Given this list of marker genes WIZ, ZNF354C, SNAI1, ZFAT, NEUROD1, MITF, ALX3, ZBTB38, ZNF181, ZNF134, PATZ1, STK16, NR1I3, ZNF260, RBMX, ZNF784, ZNF280C, ZNF468, FOXO3, KLF13, STAT5A, ZNF14, ZNF347, ZNF354B, ZKSCAN8, GCM1, GLIS1, TCF23, TEAD4, ZIM3, ZNF66, ZFP28, ZNF304, ONECUT1, HOXD8, HOXC9, RUNX1, NKX2-4, NFE2L2, ZNF8, NEUROG1, ZNF852, ZBTB10, LHX3, ZNF140, SOX18, RFX6, TBX10, ZNF18, PGR, ZNF555, SOX3, ZNF146, SATB1, RHOXF2B, ZNF671, ZNF577, ZBTB43, ZNF668, ZNF875, NRL, ZNF789, RAX, POU4F2, TEAD3, ZBTB25, HMGA1, ZNF236, TBX3, ZNF221, ATOH1, TWIST1, ZNF723, PROP1, FOXO6, EBF1, IKZF2, MEF2D, NR2E1, HOXD3, AIRE (autoimmune regulator), HDGF, CDK9, HSF2, MLXIPL, USF1, E2F5, ELF3, ZNF714, ZNF382, ZNF572, ZSCAN5DP, KLF1, E2F8, KLF14, BARX1 (NCBI Gene Id 56033), ESX1, PAX6, ZNF774, ESRRA, TBXT, HOXA10, TBX6, RAX2, ZNF735, FOXO3B, PHOX2B, ZNF614, KLF3, IRF3, ZNF274, STOX2, SLC2A4RG, ZNF280A, THRB, ZNF512B, TFDP1, ZNF630, ZKSCAN3, SRY, TRPS1, ZNF846, RFXANK, ZNF597, DLX1, SOHLH2 (spermatogenesis and oogenesis specific basic helix-loop-helix 2), NPAS3, CUX1, ZNF74 (zinc finger protein 74), ZNF562, FEZF1, PRDM4, HBP1, ZNF564, KLF18, MYCN, ATF6B, GLI4, ZNF202, ZNF444, HES1, FOXD4L3, ZNF596, EGR3, ZKSCAN1, EHMT2, TCF24, SOX6, DLX6, CEBPA, MED12, ZBTB32, HOXB3, ZNF415, ZBTB39, ZNF324, NEUROD2, HOXD9, ZNF101, ZFP92, FOSL2, FOS, ZNF287, MAFB, ZNF70, DRGX, PER1, ZNF517, ZNF169, THAP1, E2F2, ZNF680, ASCL1, FOXQ1, ZNF552, ZNF454, IRX6, DMRTB1, ZNF611, SREBF1, ZNF350, MXD1, ZNF124, KLF5 (NCBI Gene Id 688), FOXF2, HIVEP3, POU6F1, DHX36, ZNF175, ZNF7, ZNF496, OLIG2, RORA, JUND, GRHL1, RBPJ, ZNF92, HOXB1, EGR4, ZNF727, ZBTB22, NKX2-3, CEBPE, ZNF81, ACTN4, SIX5 (SIX homeobox 5), ZFP3, CC2D1B, FOXD4L6, ZNF790, ZNF799, ZNF722, DPRX, FOXP2, ZNF44, LHX5, ZKSCAN2, NCOA2, HOXC8 (NCBI Gene Id 3224), HSF4, TFAP2B, AGO1, NKX1-1, ZSCAN9, ZBTB45, NOTO, MAFG, NFATC3, TGIF1, ZNF467, NR3C1, ZNF563, ZNF624, NKX2-2, ZSCAN16, SP8, HOXC4, ZNF558, ZEB1, MSX2, HIVEP2, MYBL1, ZBTB12, SOX4, ZIK1, ZBTB24, ZNF575, IKZF1, HSF1, PURA, CHD2, NANOG, BCL6, ATF2, HIF1A, ZNF296 (NCBI Gene Id 89860), VAX2, VDR, NR4A3 (NCBI Gene Id 8013), TBX22, DHX9, ZNF793, TFDP3, STAT6, ZNF649, ZSCAN26, FOXA2, HNRNPU, SP5, TCF7L1, ZNF628, FOXF1, ZSCAN21, SIRT1, LHX6, ZNF398, ZNF648, ZNF160, PROX1, EEF1D (eukaryotic translation elongation factor 1 delta), ZNF573, ZNF337, ARX, PURB, ZNF284, MEF2B, NKX6-1, SP6, MYB, ONECUT2, HOXA3, ZNF662, ASCL4, RELA, ETV3, ZNF853, ZSCAN25, ZNF184, WT1, HOXA11, DMRTC1, ZNF595, SNAI2, ELK3, IKZF4, MYPOP, SCRT1, EN1, UTY, ZNF117, ZNF699, ZNF37A, REL, CLOCK, POU2F3, ZNF691, NFATC1, ZFP57, NFKBIZ (NCBI Gene Id 64332), GATA2, MEOX2, POU5F1, PRDM15, ZNF581, ZNF780A, ZNF142, ZNF251, JUNB (JunB proto-oncogene, AP-1 transcription factor subunit), ZNF143, HMX2, ZNF560, DMRT1, PITX1, POU3F4, RREB1, ZNF248 (zinc finger protein 248), ZNF131, DDIT3, TCF21, TBX18, ZFP90, ZNF148, POU4F3, ZNF35, NFE2L1, ZNF219, PITX2, NR2F2, ELF5 (NCBI Gene Id 2001), SP3, PITX3, HOXB7, HDAC5, IRF1, KCNIP3, FIGLA, ELK4, THRA, RBL2, BARX2, ZNF501, ZNF655, ZBED2, TBPL1, SP2, ZNF419, ZNF549, ZBTB26, NR2C2, SOX8, ARGFX, MTF2, OGG1, HOXA1, CC2D1A, TFAP2D, ZNF76, ZNF57, NHLH2 (NCBI Gene Id 90888), NFIB, ZNF891, POU2F1, ZNF682, PPARA, ZNF460, ZNF778, GTF2B, EBF4, NEUROG2, POU2F2, MYF5, ATF3, ZNF132, GRHL2, CIC, NFAT5, ZNF697, ZBED4, TET3, ZKSCAN4, POU5F1B, E2F4, VSX2, HOXB8, MYBL2, SP9, ZBTB6, ZNF491, DEAF1, EGR2, ZNF329, ZKSCAN5, JDP2, BMAL1 (basic helix-loop-helix ARNT like 1), ZNF646, ZNF621, TBX20, IRF2, E2F7, ZNF639, HNF1A, NKX6-2, PAX3, NFYC, ZNF610, HHEX, GATA1, ZFHX4, ZNF141, ZNF394, USF3, YY2, PPARD, ESR1, ZNF716, ZNF623, KLF17 (NCBI Gene Id 128209), CDC5L, BATF, CREB3, ZNF69, FOXJ2, MNT, ESRRG, ZNF425, DDN, EPAS1, AR, ZNF718, HOXA7, ZNF449, MAFK, ZNF215, ZIC5, PRDM5, TFAP2C, ZNF502, ATOH8, RPS3, ZNF785, SP4, NHLH1, SOX12, ZBTB4, ZNF416, E4F1, ZNF497, RFX7, POU6F2, DBP, NKX2-5, ZNF813, ZSCAN32 (zinc finger and SCAN domain containing 32), RB1, RXRA, TFEB, TET1, FOXD4L5, ZNF3, NR3C2, ZNF883, PRDM14, MAFA, ZNF571, TFDP2, PROX2, ZNF737, ELF4, DLX3, E2F3, ZNF383, HOXB6, ZNF705D, IKZF5, HCFC1, ZNF514, ZNF83, SIM1, TCF7L2, ZNF34, SMAD9, ZSCAN5C, OLIG1, OTX2 (NCBI Gene Id 5015), GATA4, ZHX3, BHLHE40, PKNOX1, MKX, CXorf65, ZNF880, CPHXL, PRRX1, NFX1, ZNF10, FOXD4L1, ZNF876P, NFATC4, CIART, PHOX2A, MYF6, MEF2C, NLRC5, ZNF322, DLX2, SPIC (Spi-C transcription factor), CASZ1, TEAD1, RAD23B, DMRTA1, ZNF805, ETS1, TBX19, ZNF589, OSR2, TLX1, GTF2IRD1, TPRX2, SMAD3, ZBTB20, ZNF746, HDX, NR5A1, ZNF500, ZNF516, SUB1, ZNF670 (NCBI Gene Id 93474), CDX1, POU3F2, HOXB2, ZNF681, ZNF888, ZNF333, TBX15, CARF, AEBP1, LHX1, ZNF334, JUN, ZNF177, GFI1B, STAT1, ZNF705B, AHR, RARA, CEBPB, ZNF324B, NACC1, ZNF566, ATOH7, NFE2, SMAD4, ZFP82, CPHXL2, ATF4, HIVEP1, MEF2A, ZNF492, MESP2, RUNX2, DMRTC2, RELB, PAX7, ELF1, EN2 (engrailed homeobox 2), ZNF431 (zinc finger protein 431), GSC, KLF16, PRMT5, ZNF616 (zinc finger protein 616), INSM2, ZNF100, PASD1, ZNF548, HOXC10, MED8, NFE2L3, MEIS2, PTF1A, KLF7, BATF3, ZNF341, ZNF536, LHX9, RUVBL2, ZNF736, ZNF677, TBP, ZNF586, LHX8, SOX30, HMX3, ZBTB16, FOXC1, NR4A2, LHX2, ZNF440, GLI2, HDAC1, ZSCAN31, FOXD1, TEF, ZEB2, ZNF683, SMAD5, HOXA9, IRF8, POU1F1 (POU class 1 homeobox 1), CREBRF, HES2, EOMES, ZNF253, ZNF331, SKIL, ZNF480, ZNF23, ZNF580, STAT3, ZNF471, ZSCAN29, HNF4G, ZNF879, FLI1, HOXD11, STAT4, ZNF232, CEBPG, RBBP4, ZSCAN1, BCL11B (NCBI Gene Id 64919), OLIG3, RXRG, ZNF121, SIX4, KDM6A, NR1H3, TFAP2E, NKRF, ZNF154, TFCP2, ETV5, PAX5, FOSB (NCBI Gene Id 2354), ZNF90, NFXL1, ZNF442, ZNF506 (zinc finger protein 506), ZNF320, ZNF354A, CTCF, HMGA2, SNAPC4, HDAC4 (histone deacetylase 4), SNAI3, ZNF483, GLIS3, NANOGP8 (NCBI Gene Id 388112), ZNF25, ZNF892, HIC2, ZNF524, GSC2, ZNF302, SPIB, TBX4, ZNF266, MSGN1, ZNF404, SOX14, BACH2, ZNF205, DUXB, HOXA2, ZNF165, FOXB2, IRX4, ZNF519, LYL1, MGA, MACROH2A1, NCOA1, CDX2, VEZF1, NKX3-1, GBX2, ZNF865, BCOR, ZNF644, TFE3, IRX3, VAX1, ZNF485, SOX17, MESP1, ETS2 (ETS proto-oncogene 2, transcription factor), ZNF486, ZNF345, ZNF79, ZNF470, ZNF626, ZNF584, NPAS4, MXD3, SCX, KLF9, STOX1, FOXE1, SNAPC3, OVOL3, LMX1A, ZNF75A, ZNF479, NKX3-2, ZNF264 (NCBI Gene Id 9422), EZH2, ZGPAT, PPARG, CALCOCO1, RBL1, ANHX, HOXC13, ZNF335, ZNF766, IRX5, RUNX3, PRRX2, ZNF696 (NCBI Gene Id 79943), ZNF821, MECOM, KDM2B, PBX3, NSD1, SIX1, CDX4, ZNF620, ZNF180, SOX7 (SRY-box transcription factor 7), NPAS1, BHLHE23, ZNF837, SALL2, IRX2, HES3, MYOG, HOXD1 (NCBI Gene Id 3231), ZNF527, MLX, BMAL2, STAT5B, VENTX, TBX5, LEF1, MXD4 (NCBI Gene Id 10608), ZNF254, DUX4, ATF6, ZNF256, GATA3, SIX3, ZNF17, FOXP4, BPTF, ZNF317, H2AZ1, ZFP37, ZNF20, GMEB1, ZNF174, ZNF358 (zinc finger protein 358), TFAP4, MYOD1, LEUTX, PLAGL1, ZSCAN10, ZNF286B, ZNF30 (NCBI Gene Id 90075), NFATC2, THRAP3, ZNF283, ZNF710, NKX1-2, BHLHA9, ZNF446, CREB3L2, ZNF429 (zinc finger protein 429), DMRT2, ZNF436, PRDM1, KLF4, FOXD3, ZNF768, SUZ12, SP1, DMRTC1B, FOSL1, FOXO1, ZNF569 (zinc finger protein 569), SRF, ZNF135, IKZF3, SUV39H1, NR1D1, MTF1, ZNF713, ZNF530, PAX8, GMEB2, ZFP14, ARNT, BBX, ZNF707, ZNF777, ZNF280B, NR2F6, ZNF311, EMX1, NKX2-1, ZNF417, NR1I2, CREM, MSX1 (msh homeobox 1), CTCFL, TFEC, NFIC, BATF2, ZNF550, CRY1 (NCBI Gene Id 1407), SOX11, KLF6, ZNF24 (NCBI Gene Id 7744), ZBTB1, FOXC2, HLF, MAFF (MAF bZIP transcription factor F), FOXB1 (NCBI Gene Id 27023), PURG, MXI1, ESR2, PRDM16, TAL1 (TAL bHLH transcription factor 1, erythroid differentiation factor), PRDM2, MZF1, HES6, GSX1, RXRB, ZNF559, TP63, ZNF679, NEUROD6 (neuronal differentiation 6), HELT, ZNF676, ASCL2, TWIST2, CREB3L4, ASCL3, YY1, ZSCAN30, IRF5, FEV, ST18, SOX15, WBP2, TP73, ZSCAN18, TRIM24, MYT1L, ZNF418, E2F1, ZNF182, HIF3A, HOXB4, ZBTB48, ZNF362, USF2, ATF7, KLF2, NPAS2, FOXO4, HNF4A, FOXI1, ZNF711, ATF1, PDX1, GFI1 (NCBI Gene Id 2672), OVOL1, NFYB, ZBTB7C (NCBI Gene Id 649379), NEUROG3, ZNF625, HOXC5, ZNF239, FOXP3, DLX5, ZNF664, PBX1 (PBX homeobox 1), ZSCAN4, ZNF732, ZNF740, PAX9, ZNF700, ZNF32, TP53, ZNF395 (NCBI Gene Id 55893, zinc finger protein 395), NKX6-3, SKOR1, TOP1, FEZF2, FOXA3, ZNF75CP, KLF8, KLF15, ESRRB, TAL2, NFYA, ZNF763, HEY1, ZNF665, ZNF487, ZNF613 (zinc finger protein 613), OTP, ZNF12, MSC, FOXD4L4, SIX2, BCL6B, MYNN, NR2F1, ZNF528, ZNF423, ZNF749, ZNF540, SMYD3, HNF1B, NRF1, CCAR1, GTF2A1, ZNF878, LRRFIP1, SMAD1, BHLHE22, ZNF556, KLF10, ZBTB5, ZNF189, ADNP, ZSCAN12, ZNF250, ZNF568, SOX13, ZNF529, ETV4, ZNF557, ZNF19, GLI3, DNMT3A, ZNF343, RFX4, HES4, NFKB2, ZNF772, SIX6 (NCBI Gene Id 4990), KAT2B, RFX2, ASCL5, TCFL5, ZBTB9, ZNF16, ENO1, RBAK, H3-3B, FOXS1, MAF, ZNF764, ZNF641, HOXD10, ZNF80, ZBTB2, THAP11, ZNF835, ZNF860, SATB2, ZNF546, ZNF791, CREB3L1, ZNF212, ALX1 (NCBI Gene Id 8092), ZIC2, ZNF490, ZNF599, ISL1 (ISL LIM homeobox 1), ARNT2, SOX5, PKNOX2, NR4A1, ZNF77, ZNF561, SALL1, SOX21, ZBTB8A, FOXE3, HOXA4, ZSCAN5A, ZBTB33, MUC1, SOX2, NKX2-8, HOXB5, ZNF567, ZNF684, ZFY, TCF7, MTA1, NR2E3, ZNF773, ZNF136, CREB5, HES7, SOX10, KLF11, GATA5, GLI1 (NCBI Gene Id 2735), ZNF430, SIM2, OVOL2, ZNF704, ZBTB17, HINFP, POU5F2, ZNF273, ZNF829, ZNF280D, TCF15, ZNF823, ZNF844, ZNF133, MYCL, ZNF433, FOXK1, NFIL3, ZNF619 (NCBI Gene Id 285267), IRF7, FOXP1, DMRT3, CREB1, TBR1, RFX5, HAND2, FOXJ1, ZSCAN5B, TBX21, ZNF391, MACROH2A2, GLIS2, HMX1, PLAG1, ZNF582, SARS1, ZNF554, BARHL2, ZNF534, ZNF263, ZBTB41, ZNF396, EVX1, RFX1, HEY2, ETV1, ZNF761, ZNF692, MYC, HEYL, ZIC3, YAP1, RBPJL, SOX1, LITAF, ZNF367, NRIP1, ZIC4, TBX1, BCL11A, EBF3, TFAP2A, POU3F1, HESX1, ZNF660, HOXC11 (NCBI Gene Id 3227), MAZ, NOBOX, MIXL1, ZNF559-ZNF177, ZNF705G, ZNF565, FERD3L, ONECUT3, SOX9, ZNF669, SKI, TAF1 (TATA-box binding protein associated factor 1), GATA6, ZFP30, NR1H2, BHLHA15, ZNF397, SKOR2, MLXIP, ZNF366, CHD7 (chromodomain helicase DNA binding protein 7), ZNF85, DUXA, RFX3, ZNF275, ZNF775, ETV7, HOXD13 (NCBI Gene Id 7859), SCRT2, TFCP2L1, ZNF114, ZNF583, ETV6, MED1, ZBED1, ZNF730, ZC3H8, ZNF776, ZSCAN2, RHOXF2, ZSCAN20, ZNF195, ZNF439, BHLHE41, CREB3L3, ZNF257, MEIS1, ZNF461, FOXL1, BARHL1, ZNF426, ZNF675, FOXI3, DMBX1, NEUROD4, ZNF277, XBP1, ZNF300, DACH1, IRF4, NR1D2, SPI1, SMAD2 (SMAD family member 2), ZNF420 (zinc finger protein 420), HAND1, NANOGP1, RHOXF1, FOXD4, ZNF551, ZNF667, HES5, ZNF607, PRDM11, GBX1, ZNF543, HOXA6, ZNF98, ZBTB37, EGR1, RARG, ZNF750, TCF4 (NCBI Gene Id 6925), ZNF408, ZBTB7B, PAX2, MAX, SREBF2, REST, RORC, ETV2, ELK1, GABPA, PAX1, NR5A2, FOXA1, ZNF765, BSX (NCBI Gene Id 390259), LMX1B, TBX2 (T-box transcription factor 2), H3-3A, BACH1, EMX2, HDAC6, ZNF627, ZNF578, NFIA, ZNF410, PBX2, ZNF570, NFIX, ZNF441, SAFB, HOXC6, ZNF587B, NTN1, IRF6, OTX1, IRF9, DACH2, ZNF695, E2F6, ZFP42, ZNF93, TCF3, ZNF724, ALX4, ERG, DMTF1, ZBTB49, POU4F1, ZNF816, ZNF701, BORCS8-MEF2B, ZNF75D, TEAD2, ZFHX3, DMRTA2, YBX3, GZF1, LHX4, EVX2, ZNF286A, ZNF547, ZNF217, FOXM1, ZNF678, ZFP69, TCF12, TARDBP, ZNF709, ZNF211, CEBPD, FOXJ3 (forkhead box J3), ZNF689, HOXD4, MEOX1, ISX, ZNF281, PEG3, RORB, RFX8, FOXK2, ZFP1, ZNF705EP, ZIC1, EHF, ZBTB34, CUX2, ZBTB14, OSR1, ZBTB11, ZNF705A, ZNF780B, ZKSCAN7, IRX1, NR1H4, ZSCAN23, KDM6B, FOXL2, EBF2, NR2C1, NFKB1, ZNF792, ZNF587, HOXA5, ZNF674, ZNF138 (NCBI Gene Id 7697), MYBBP1A, NACC2, NTN3, DLX4, RARB, FOXI2, ZSCAN22, HOXA13, HOXB13, FOXD2, STAT2, ZNF728, UBP1, HOXB9, NR6A1, ZFHX2, ZFX, RFXAP, PAX4, ZBTB7A, ZFP41, ZNF71, ATF5, CRX, KLF12, SP7, INSM1, ZNF355P, ZFP69B, GCM2 (NCBI Gene Id 9247), ZNF213, NKX2-6, GRHL3, ZNF28, POU3F3, ZNF443, ZFP2, here is a description of the gene set: Binding to a specific sequence of DNA that is part of a regulatory region that controls the transcription of a gene or cistron by RNA polymerase II. Human Gene Set: GOMF_RNA_POLYMERASE_II_TRANSCRIPTION_REGULATORY_REGION_SEQUENCE_SPECIFIC_DNA_BINDING studied in species Homo sapiens